The following is a description of a gene set: species: Mus musculus from publication Chen Y, Wang X (PMID 31504780) Mouse Gene Set: MIR_181B_5P Genes predicted to be targets of miRBase v22 microRNA mmu_miR_181b_5p in miRDB v6.0 with MirTarget v4 prediction scores > 80 (high confidence targets)., and this is the list of marker genes: Plcl2, Rlim, Gpr22, Rbm26, Ssx2ip, Zfp960, Pcdha1, Epha4, Rnf34, Tecpr2, Zfp36l1 (zinc finger protein 36, C3H type-like 1), Nucks1, Rnf182, Nus1, Zfp1009, Zdhhc17, Larp4, Palb2, Pnisr, Igdcc3, Esr1, Adcy9, Pbx1, Gata6, Slitrk1 (NCBI Gene Id 76965), Txndc12, Atp2b2, Spire1, Rbm46, Abtb2, Zfp867, D430041D05Rik (NCBI Gene Id 77092), Cecr2, Atxn1, Heca, Tnf, Cfap90, Pdcd6ip, Ubl3, Klhl42, Gm20939, Mpi, Pcdha4, Gls, Dnajc13, Prkcd, Mmp14 (NCBI Gene Id 17387), Rassf8, Zbtb4, Pou2f1, Nr1d2, Zfp1008, Zbtb43, Greb1l, Lin28b, Zfp825, Gm6710, Pcdha7, Zfp935, Carf, Afg3l2, Hmbs, Agfg1, Mtx3, Psap, Osbpl3, Nfat5, Slc35f3, Cpne2, Gatm, 1700066M21Rik, Tns1, Arl13b, Zfp931, Slf2, Patl1, Cpeb4, Gm14322, Clasp1, Clasp2, Kcnq5, Hey2, Ipmk, Lemd3, Nipal4, Pcdha11, Tmem165, Rai1, Ube2b, Baz2b, Pcdhac1, Lrrc32, Rsad1, Cdc40, Zfp958, Tmed4, Taok1, Spry4, Tgfbr1, Zfp600, Ptbp3, Cnksr2, Gpd2, Zfp120 (zinc finger protein 120), Plekhj1, Pcdha5, Dnajc21, Rufy3, Ankrd44, Pals1, Zfp850, Limch1, Tulp4, Gabra1, Pknox2, Ubp1, Mdh1b, Lox, Fnip2, Ythdc2, Hsp90b1, Ccnj, Ino80d, Specc1l, Zfp704, Htr1a, Sin3b, Card11, E2f5, Atg5, Tmem94, Naa15, Zfp975, Lif, Nr6a1, Trim2, Ippk, Pax9, Hoxa1, Grik2, Cacnb2, Adamts5, Dido1, E2f7, Zic2, Hic2, Itsn2 (NCBI Gene Id 20403), Dusp6 (NCBI Gene Id 67603), Fam3c, Pcdha9, Dlgap2, Pcdhac2, Slc25a37, Dclk1, Zfp967, Usp42, Phtf2, Spty2d1, Gm6712, Zfp936, Nkain2, Bcl2l11, Septin8, C2cd5, Nr2c2, Gm14391, Mybl1, Tmeff1, Iqschfp, Ttpa, Acsl4, Bclaf1, Spink2, Zfp869, Papolg, Adamtsl1, Zfp619, Rps6ka3, Ago2, Etl4, Gpd1l, Rorb, Zfp317, Zfp97, Zfp966, Crim1, Dio2, Nek7, Creb1 (NCBI Gene Id 98624), Zfp101, Rabgef1, Gm14296, H2-K1, Rex2, Mtf2, Esm1, Zfp970 (zinc finger protein 970), Tcerg1, Lrrc8e, Bend3, Kmt2c, Zfp781b, Tnfaip1, Rin2, Atf7ip2, 2010315B03Rik, Ttl, Spice1, Slc25a36, Map4k4, Msantd3, Dennd4c, Ap1s3, Dlg2, Ddx55, Zfp280d, Prdm4, Acvr1c, Grm5, Atp2b1, Mlf1, Zfp976, Gm14325, Cep97, Pabir2 (NCBI Gene Id 78755), Drd1, Umad1, Mideas, Zfp800, Ttc39b, Pdap1, Clec10a, Cnksr3, Zdhhc7, Ppip5k2, Pcdha10, Morc3, Jarid2, Lmo1, Sema4g, Mapk1, Klhl29, Prrc2c, Wsb1, Lrba, Ipo8, Mfsd6, Tnfsf10, Srsf7, Fmnl2, Trak1, Prtg, Pcdha8, Sfmbt1, Cdon, Zfp14, Arf6, Crebrf, Ncoa2, Golga1, Stxbp6, Chic1, Rad21, Ercc5, Ss18l1 (SS18, nBAF chromatin remodeling complex subunit like 1), Gfpt1, Tbc1d4, Ahnak, Cdc42bpa, Pcdha6, Gse1, Trub1, Slc4a10, Ppfia1, Epc2, Birc6, Dram1, Zfp36l2, Cblb (Casitas B-lineage lymphoma b), Adarb1, Usp33, Ddx3x, Nr4a3, Prom2, Zfp930, Rala, Zfp808, Armcx3, Eya3, 2210418O10Rik, Thrb, Tent4b, Cluh, Nr3c1, Gigyf1, Klhl5, Rassf1, Lclat1, Med8, Zic3, Hoxa11, Trim71, Nexmif, Bhlhe40, Pcdha2, Fbxo33, St8sia4, Zfp973, Dock4, Klf6, Ap4e1, Peak1, Tspan13, Zbtb7a, Klf15, Brd1, Pcdha12, Hycc2, Jdp2, Cbx7, Gm14326, Apba1, Acvr2b, Ythdf3, 5730507C01Rik, Etv6, Nmnat3, P2ry10, Man2a1, Slc2a3, Zfp951, Il1a, Ccdc122, Zfp458, Rbbp7, Atp2b3, Sox6, Btbd3, S1pr1, Sgpp1, Syne1, Gskip, Tada2b, Smap1, Lyrm1, Nab1, Pi15, Qser1, Zfp934, Stim2, Prox1, Gpsm1, Tnfrsf11b, Ano1, Fign, Dmxl2, Entpd6, Zfp971, Pi4k2b, Jade2, Htr1f, Xpo7, Abi3bp, Adam11, Mboat2, Sim1, Glrb, Zfp780b, Kpnb1 (karyopherin subunit beta 1), Tsc22d2, Mturn, Ap1g1, Cyp2c39, Ncald, Pcdha3, Slc7a13, Cbfa2t3, Hipk3, Cpsf6, Carm1, Sec24a, Rnmt, Zfp810, Cntn4, Sowaha, Rps6kb1, Esco1, Dcbld2, Schip1 (NCBI Gene Id 30953), N4bp2, Togaram1, Tbc1d1, Sik3, Mycbp2, Phlda1 (NCBI Gene Id 21664), B4galt1, Kmt2a, Nwd2, Kcnh1, Tab3, Ercc8, Ccp110, Cdyl, Lhx9, Ralgapb, Mb21d2, Zfp965, Nova1 (NOVA alternative splicing regulator 1), Mtpn, Oxsm, Scyl3, Mamdc2, Hoxc8, Wdr82, Dnaja4, Hibch, Clip1, Aldh3a2, Adamts6, Grb10, Wnk1, Phf20l1, Sec24c, Kcna4, Anapc16, Zfp980, Mier3, Adamts1, Ppp3r1, Cpd, Mfsd1, Zbtb41, Scamp2